Given this list of marker genes Nod2, Ccl21a, Thbs1, Nod1, Fgl2, Slc11a1, Ccr7, Ccl19, Cd68, Cd74, here is a description of the gene set: Any process that modulates the frequency, rate, or extent of dendritic cell antigen processing and presentation. Mouse Gene Set: GOBP_REGULATION_OF_DENDRITIC_CELL_ANTIGEN_PROCESSING_AND_PRESENTATION studied in species Mus musculus